Given this list of marker genes Sytl4, Pde4c, Adcy8, Agt (NCBI Gene Id 11606), Nr1h4, Isl1, Klf7, Trpm2, Gck, Acsl4, Srebf1, Cd38, Sri, Tcf7l2, Alox5, Ptprv, Adra2a, Orai1, Pfkl, Prkn, Mup1, Mtnr1b, Ffar2, Gper1, Hadh, Myh9, Glud1, Cpt1a, Gpr68, Cacna1c, Rest, Capn10 (calpain 10), Ucn3, Hcfc1, Trpa1, Ptpn11, Gcg, Doc2b, Sidt2, Crh, Slc30a8, Anxa7, Uts2, Clock, Bmal1, Abca12, Sstr5, Inhbb, Kcnj11, Cacna1d, Nnat, Ano1, Ppp3cb, Il1b, Oga, Piwil4, Ghrl, Gnaq, Pim3, Camk2n1 (NCBI Gene Id 66259), Mir200a, Gpld1, Ccl5, Atg7, Gna11, Slc9b2, Mup5, Il6, Gnas, Abat, Per2, Gnai1, Snap25, Mpc2, Myt1, Nr1d1, Ppp3ca, Slc2a2, Crhr2, Cask, Epha5, Adcy5, Jak2, Syt7, Ppard, Sox4, Mup3 (major urinary protein 3), Lrp1, Gipr (gastric inhibitory polypeptide receptor), Pde8b, Abcc8, Birc5, Mlxipl, Arrb1, Rbp4, C1qtnf12, Kcnj6, Trpm5, Glp1r, Mtnr1a, Bad, Cnr1 (NCBI Gene Id 12801), Sirt4, Ptpmt1, Pfkfb2, Fkbp1b, Fbn1, Tfap2b, Ptger3, Fam3d, Mup11 (major urinary protein 11), Mcu, Rfx3, Mir130a, Ghsr, Ptbp1, Hmgcr, Pck2, Pick1, Npff (NCBI Gene Id 54615), Trpc1, Tbc1d1, Lepr, Glul, Tnf, Tardbp, Mir410, Casr, Osbp, Jagn1, Sirt1, Trh, Oxct1, Tunar, Chrm3, Rfx6, Mup4, Bglap2, Abcg1, Dynll1, Kcnb1, Tcirg1, Foxa2, Ccn3, Slc16a1, Sybu, Cdk16, Stxbp5l, Cftr, Rapgef4, Nadk (NAD kinase), Gpr27, Nr0b2, Kif5b, Pfkm (phosphofructokinase, muscle), Psmd9, Hnf4a, Sfrp1, Hnf1a, F2rl2, Aacs, Sirt3, Brsk2, Nlgn2, Baiap3, Zbed6, Cacna1e, Prkaca, Slc8b1, Stx4a, Trpm4, Cela2a, Eny2, Stxbp4, Ensa, Gpr39, Rac1, F2rl1, Sirt6, F2, Pdx1, Rph3al, Prkcb, Fto, Nos1, C2cd2l, Nos2, Pde3b, Gnao1, Map4k4, Ucp2, Acvr1c, Plcb1, G6pc2, Lrrc8a, Uqcc2, Midn, Nkx6-1, Serp1, Cartpt, Vsnl1, Ffar1, Kcnq1, Ffar3, Eipr1, Itpr1, Ifng, Irs2, Drd2, Gprc6a, Prkar1a, Foxo1, Gip, Lep (NCBI Gene Id 16846), Hif1a, Efna5, Prkce, Lrp5, Irs1, Myrip, Ncoa6, Blk, Gja1 (gap junction protein, alpha 1), Chga, Gnaz, Slc25a22, Syt9, Pla2g6, Mup2, Pde1c, Rptor, Stim1, Tiam1, Hmgn3, Ndufaf2, Tm7sf3, here is a description of the gene set: Mouse Gene Set: GOBP_REGULATION_OF_INSULIN_SECRETION studied in species Mus musculus Any process that modulates the frequency, rate or extent of the regulated release of insulin.